The following is a description of a gene set: Human Gene Set: GOCC_MRNA_CLEAVAGE_FACTOR_COMPLEX species: Homo sapiens Any macromolecular complex involved in cleavage or polyadenylation of mRNA molecules., and this is the list of marker genes: WDR33, NUDT21, CPSF4, SSU72L2, ZC3H3, CSTF2T, SSU72L1, CSNK1A1, SSU72L4 (NCBI Gene Id 441584), CPSF6, CSTF1, CPSF4L, SSU72L6, PIP5K1A, SYMPK, CSTF2, SCAF8, CLP1, CSTF3, CPSF3, CPSF7, FIP1L1, SSU72, SSU72L5, CPSF1, PCF11, SSU72L3, TUT1, CPSF2